The following is a description of a gene set: SUMOylation of transcription factors species: Mus musculus Mouse Gene Set: REACTOME_SUMOYLATION_OF_TRANSCRIPTION_FACTORS, and this is the list of marker genes: Mta1, Hic1, Sumo2, Pias4, Foxl2, Sumo1 (small ubiquitin-like modifier 1), Ube2i, Pias2, Tfap2c, Pias1, Pias3, Sumo3, Trp53bp1, Mitf, Sp3